The following is a description of a gene set: Human Gene Set: CEBP_Q2_01 species: Homo sapiens Genes having at least one occurrence of the motif NTTRCNNAANNN in the regions spanning 4 kb centered on their transcription starting sites. This matches the CEBPA transcription factor binding site V$CEBP_Q2_01 (v7.4 TRANSFAC)., and this is the list of marker genes: NADK, TNFSF13B, ZFP36L1, CLN5, DCN (decorin), LNPK, JADE3, RARB, PPP1CB, CALR, H3-3B, RUVBL2, SIK3, PRRC2A, TMEM104, CRH, PIGP, SEMA6D, CCL3, KIF2B, ARRDC3, EYA1, ATAD2, LRRTM3 (NCBI Gene Id 347731), ADH7, HOXA1, CUEDC1, MOSPD2 (NCBI Gene Id 158747), ANGPT1, ASAH2, STC2, SYNCRIP, TTC22, ZBTB20, CFL2, PLCB1, PALS2, RGR, LINC00472, FBXW7, FOXP3, GYS1, SULF1, ARHGEF38, YRDC, MAP2K3, JUN, PER1 (NCBI Gene Id 5187), DYRK3, CALML4, IL19, CCL8, F9, TM2D2, HIVEP3, DENND2D, C1orf122, USP9X, HDAC4, ANO1, SLC39A13, USP34, CSDE1, DLG2, PDE4D, SOX5, PLS1, NFE2L2, ERG, DBH, WNT5A, LUZP1, CAVIN2, HERC4, TNNC2 (NCBI Gene Id 7125), ASGR2, TP63, XKRX, FGA, PAX8, WEE1, TSPAN5, LINC00114, SNX12, IL1RAPL1, ADAM9, ADRB2, LRIT3, WNT10B, ACSL5, FIGN, APC (APC regulator of WNT signaling pathway), ELAVL2, CHD2, PPP1R3D, ARF6, PLCB2, DMD, CHST15, CEP41, CEP120, TXLNG, ALDH1A2, FAHD1, ASGR1 (NCBI Gene Id 432), NCKAP5, LHX6, NDUFA4L2, NDP, HOXB7, CCN1, RAB2A, EFEMP1, TOB1, ETV6, TBR1, CLASP1, ABHD6, EIF4A2, NAT9, HAGH, MTTP, EPHB6, MBNL1, CLDN8, CGN, PCDH7 (NCBI Gene Id 90855), TMBIM6, S100PBP, PLPP5, NEUROG1, ARID1B, ESR1, TESK2, ID3, HOXA2, TNS2, MKNK2, THRA, FBXO40, BDNF, STMN1, KLF12, NFKBIZ, TSC22D1, CITED4, MITF, MYH10, AP1S2, TNFSF15, PITX2, ACAN, TBXAS1, SPRY4, SLC25A35 (NCBI Gene Id 399512), BCL6, KRT23, IL27, MAP3K3, DYNC1H1, KLF5, CEPT1, PPL, XDH, ALB, CRIM1, NRXN3, NREP, PCDHB4, ATP13A4, PRKG1, FGF14, CADM1, HOXA10, S1PR5, NEO1, HOXC4, SERPINA7 (NCBI Gene Id 6906), SLIT3, SBSN, WNT6, SPRR1B, HOXA5, CDKN1C, CBX4, RBM4, UBE2E2, SOBP, MREG, FBXL14, DOCK3, RNF17, MIDEAS, DENND4A, CASK, ETV5, TFE3, WNT3, PALS1, H1-2, HOXD9, MARCHF1, ZNF428, LONRF3, FOXN3, LYPD1, LCOR, SPRED1, TNFSF14, MLH3, TSHZ3, ADAMTS2, CAMKMT, FAM91A1, TRIB1, ASCL2, MYH4, FAM217B, MMP27, SLC12A1, TLR8, FMO2, KCNJ13, YWHAG, BEND4, GABRR2, PCTP, LEMD2, SIAH3, LIPG, SPIB, PLA2G4A, TCF7L1 (NCBI Gene Id 83439), TTLL6, NFIX, ADAMTS5, MED12L, HOXC6, FOXP1, RHOB, PREPL, TCF12, BNC2 (basonuclin zinc finger protein 2), NRP2, C2CD2, C2CD5, SIRPA, NPVF, EGFR, LMO4, CALD1, ERF (NCBI Gene Id 2077), GPC4, PRDX3, RIN3, NFIL3, IL1R2, SLC40A1, SPAG9, CIPC, SPTLC2, PTEN, STC1, IL1F10 (interleukin 1 family member 10), DLX1, MAP2K6, CITED1, BMX, PCDHGC3, SLC6A15 (solute carrier family 6 member 15), EBF2, TBX6